The following is a description of a gene set: The attachment of one cell to another cell via adhesion molecules that are at least partially embedded in the plasma membrane. studied in species Mus musculus Mouse Gene Set: GOBP_CELL_CELL_ADHESION_VIA_PLASMA_MEMBRANE_ADHESION_MOLECULES, and this is the list of marker genes: Slitrk2, Dsg1c, Lrfn3 (NCBI Gene Id 233067), Ptpn23, Pcdhgc3, Cdh3, Chl1, Crb2, Cldn15, Dscam, Dsc1, Cdh4, Igsf11, Pik3cb, Lrfn5, Dchs1, Pcdh20, Pcdh10, Kirrel3, Alcam, Epha3, Arvcf, Cldn1, Cldn11, Nrxn1, Cldn4, Ptprs, Dscaml1, Clstn2, Cdh2, Cdh8, Cd164, Flrt3, Kifap3, Pcdh15, Elfn1, Cntn5, Cldn7, Mmp24, Mag, Cxadr, Palld, Ptprm, Pcdhb8, Amigo2, Selp, Pcdha4, Efna5, Cdh9, Dsc3, Sele, Mpz, Cd177, Ric8a, Cbln1, Lrrc4, Grid2, Fgfrl1, Cdh13, Nectin2, Jaml, Cdh26, Ceacam2, Ptprd, Unc5d (NCBI Gene Id 320828), Itgal, Amigo3, Slitrk1, Dsg2, Pcdh8, Pcdha9, Lrfn4, Celsr3, Clstn1, Apoa1, Cdh23, Elfn2, Pcdhb6, Mbp, Mdga1, L1cam, Klf4, Il1rap, Mcam, Dsg4, Cdh6 (cadherin 6), Cdh12, Pcdhga12, Hmcn1, Cldn14, Itga4, Lrrc4b, Wnk1, Celsr1, Pcdhb14, Cx3cl1, Tenm2, Cldn23, Igsf9b, Lypd10, Cldn19, Pcdha10, Cldn2, Dsg3, Cdhr18, Plxnb3, Lgals1, Cdhr2, Myadm, Cldn3, Il10, Cdh18, Ptprt, Sdk2, Lrrc4c, Ajuba (ajuba LIM protein), Crb1, Cadm2, Itga5, Sdk1, Nptn, Celsr2, Nexn, Pecam1, Mdga2, Cdh5, Sparcl1, Plxnb2, Sell, Adgrl3 (adhesion G protein-coupled receptor L3), Cdhr5 (NCBI Gene Id 72040), Cldn9, Fat2, Dab1, Itga3, Nrg1, Dsg1a, Magi2, Prtg, Myot, Cldn18, Cdh16, Pcdhga4 (NCBI Gene Id 93712), Colec10, Cldn10, Cdh24, Nlgn1, Tnfaip3, Igsf9, Scarf2, Tenm4, Clstn3, Tgfb2, Adgrl1, Mapk14, Cdh22, Cdh20, Dsg1b, Fat4, Cdhr3, Crtam, Ceacam5, Cdh19, Tenm3, Pvr, Cd6, Acvr1, Taok2, Slitrk3, Cdhr1, Cplane2, Cldn16, Cldn17, Nrcam, Pcdh17, Umod, Pcdhb18, Nectin1, Scarf1, Cldn5, Ntng2, Pcdh18, Map2k5, Epcam, Cldn6, Atp2c1, Ntng1, Tgfbr2, Cadm1, Gata5, Il1rn, Bsg, Cdh11, Slitrk5, Vcam1 (NCBI Gene Id 22329), Cldn12, Lgals9, Emb, Ceacam1 (CEA cell adhesion molecule 1), Fat3, Pcdh19, Lypd11, Mapk7, Igsf21, Ptprf, Hmcn2, Cadm4, Pcdh1, Cdh10, Il1rapl1, Pcdh12, Adipoq, Nectin3, Robo1, Bmp2, Cadm3, Amigo1, Pcdha7, Cldn8, Cntn6, Cdh17, Cldn22, Nectin4, Dsc2, Esam, Cd24a, Mypn, Gpc4, Robo2, Ret, Cdh1, Cdh7, Cdh15